The following is a description of a gene set: studied in species Mus musculus The process in which the nucleoprotein complex (composed of the broken single-strand DNA and the recombinase) searches and identifies a region of homology in intact duplex DNA. The broken single-strand DNA displaces the like strand and forms Watson-Crick base pairs with its complement, forming a duplex in which each strand is from one of the two recombining DNA molecules. Mouse Gene Set: GOBP_DNA_STRAND_INVASION, and this is the list of marker genes: Psmc3ip, Dmc1, Rad51d, Xrcc2, Wrn, Rad51